Given this list of marker genes BTD, MCCC1, ACACB, SLC5A6, PC (pyruvate carboxylase), MCCC2, PCCB, HLCS, PCCA, ACACA, PDZD11, here is a description of the gene set: Human Gene Set: REACTOME_BIOTIN_TRANSPORT_AND_METABOLISM Biotin transport and metabolism species: Homo sapiens